The following is a description of a gene set: Any process that results in a change in state or activity of a cell or an organism (in terms of movement, secretion, enzyme production, gene expression, etc.) as a result of a fatty acid stimulus. studied in species Mus musculus Mouse Gene Set: GOBP_RESPONSE_TO_FATTY_ACID, and this is the list of marker genes: Alad, Gnpat, Akr1c19, Tlr2 (toll-like receptor 2), Pcsk1, Gipr, Nfatc4, Cav3, Pdk4, Xrcc5 (X-ray repair complementing defective repair in Chinese hamster cells 5), Foxp1, Akr1c13, Ptafr, Scd1, Hmgcs2, Pdx1, Ffar2, Ppp5c, Zc3h12a, Hes1, Srebf1, Cd36, Scd4, Cldn1, Foxo3, Kcnk2, Gldc, Akr1c18 (aldo-keto reductase family 1, member C18), Ucp2, Ccl2, Cps1, Slc2a2, Tbxas1, Ucp1, Ass1, Ldlr, Trpv4, Plcb1, Snhg20, Aacs, Scd3, Cdk4, Id3, Foxo1, Hmox1, Smarcd1, Irs1, Ffar1, Bola3, Edn1, Ptgs2, Tlr4, Ffar3, Kcnk4, Or51e2, Ranbp1, Oaz1, Scd2, Lpl (lipoprotein lipase), Adipoq, Pik3ca, Adipor2, Pid1, Zfp683, Cat, Ildr1, Acsl1, Cpt1a, Pdk3, Dgat2, Nr1h4, Akr1c12 (aldo-keto reductase family 1, member C12), Src, Sox9